The following is a description of a gene set: Mouse Gene Set: GOBP_AMIDE_CATABOLIC_PROCESS species: Mus musculus The chemical reactions and pathways resulting in the breakdown of an amide, any derivative of an oxoacid in which an acidic hydroxy group has been replaced by an amino or substituted amino group., and this is the list of marker genes: Uox, Nt5c, Ftcd, Pipox, Urah, Aass, Urad, Dnph1, Xdh, Kynu, Tdo2, Nit1, Ada, Pnp, Pm20d1, Nt5c2, Hal, Allc, Nt5c1a, Aadat, Amdhd1, Gda, Nt5c1b, Uroc1, Dlst